The following is a description of a gene set: studied in species Homo sapiens Genes predicted to be targets of miRBase v22 microRNA hsa-miR-1915-5p in miRDB v6.0 with MirTarget v4 prediction scores > 80 (high confidence targets). from publication Chen Y, Wang X (PMID 31504780) Human Gene Set: MIR1915_5P, and this is the list of marker genes: SULF1, MYPN, DIO2, CHN1, ZNF785, IL1RN, ZCCHC24, ZFYVE16, NCOA2, MCU, FOXF1, ZNF813, RAB14, PKP1, SGIP1, ANKRD66, MTMR3 (myotubularin related protein 3), HS6ST3, STIMATE, PCLAF, ACSS3, ZNF600, KRT40, SSUH2, EAF1, RBAK, SYT4, NOP14, CEP70, NAV1 (NCBI Gene Id 89796), ZGPAT, CNKSR2, RAB1B (RAB1B, member RAS oncogene family), ZNF138, CALU, JADE1, TCP10L, ZNF35, ZNF468, MAP2K4, MTMR9, DAPK1, ZNF28, BET1L, TFE3, AAK1